Given this list of marker genes PSMA8, PSMA1, PSMA4, PSMA6, PSMA5, PSMA3, PSMA7, PSMA2, here is a description of the gene set: The proteasome core subcomplex that constitutes the two outer rings of the proteasome core complex. An example of this component is found in Mus musculus. Human Gene Set: GOCC_PROTEASOME_CORE_COMPLEX_ALPHA_SUBUNIT_COMPLEX studied in species Homo sapiens